The following is a description of a gene set: Any process that results in a change in state or activity of a cell or an organism (in terms of movement, secretion, enzyme production, gene expression, etc.) as a result of an iron(II) ion stimulus. studied in species Homo sapiens Human Gene Set: GOBP_RESPONSE_TO_IRON_II_ION, and this is the list of marker genes: MAP1LC3A, ATG5, PDX1 (pancreatic and duodenal homeobox 1), LCN2, SNCA, BECN1 (beclin 1), ACO1